Given this list of marker genes STX1A (NCBI Gene Id 6804), EVC, SOX4, ZIC3, SMARCA4 (NCBI Gene Id 6597, SWI/SNF related, matrix associated, actin dependent regulator of chromatin, subfamily a, member 4), NCF1, METTL27, SLC35D1, SMARCD1, SMARCB1, SHOC2, GTF2IRD1, EIF5A, NSD1, BAZ1B, NOTCH1, HOXA13, GTF2I, COL11A1, AFF4, PRKACB, INPPL1, LIMK1, FGFR1, DPF2, SMARCE1 (SWI/SNF related, matrix associated, actin dependent regulator of chromatin, subfamily e, member 1), TCTN3, NECTIN4, DYNC2LI1, EIF4H, ARID1A, UBAP2L, VPS37D, TBX3, MSX1, EVC2, RFC2, WLS, KDM1A, BUD23 (NCBI Gene Id 84118), LIG4, ATP6V1B2, RIPK4, TBL2, DPH1, SET, SUZ12, TMEM270, PPP1CB, TELO2, DNAJC30, DLL4, NSUN2, EZH2, PIGF, ELN, ARID2, PPP2R5D, CPT2, EOGT (NCBI Gene Id 79580), ARID1B, TBC1D24, GLI1, KRT5, POLR1A, CLIP2, TBX4 (NCBI Gene Id 9496), FTO, FKBP6, ZMYM2 (zinc finger MYM-type containing 2), SMARCC2, PRKACA, GTF2IRD2, SCO2 (synthesis of cytochrome C oxidase 2), ODC1, HRAS, SOX11, DPH2, SHANK3, EBF3, here is a description of the gene set: Hypoplastic toenails studied in species Homo sapiens Underdevelopment of the toenail. Human Gene Set: HP_HYPOPLASTIC_TOENAILS